The following is a description of a gene set: Mouse Gene Set: GOBP_NEGATIVE_REGULATION_OF_ALPHA_BETA_T_CELL_DIFFERENTIATION Any process that stops, prevents, or reduces the frequency, rate or extent of alpha-beta T cell differentiation. species: Mus musculus, and this is the list of marker genes: Pf4, Runx3, Foxp3, Zfp35, Loxl3, Lgals1, Socs5, Anxa1, Ascl2, Il4ra, Bcl6, Ihh, Zbtb7b, Cbfb, Hlx, Tbx21, Shh, Runx1, Jak3, Irf1, Socs1, Zc3h12a, Tnfsf4, Hmgb1, Smad7, Il4, Rc3h1, Il2, Rc3h2, Slc4a2, Gli3, Cd69, Tnfsf18